The following is a description of a gene set: Human Gene Set: PID_THROMBIN_PAR1_PATHWAY PAR1-mediated thrombin signaling events studied in species Homo sapiens from publication Schaefer CF, Anthony K, Krupa S, Buchoff J, Day M, Hannay T, Buetow KH (PMID 18832364), and this is the list of marker genes: F2RL2, PKN1, RHOA, DNM1, PRKCG, ZYX, GNAI3, MYL2, F2R, GNAZ, SNX1, GNA12, GRK3, F2, PLCB2, ROCK1, GNAI1, DNM2, NOS3, GNAQ, GNB1, PLCB3, GNA15, ARRB1, PRKCB, GNG2, TRPC6, PIK3R1, PLCB1, GNAI2, ARHGEF1, GNAO1, SNX2 (NCBI Gene Id 6643), GNA14 (G protein subunit alpha 14), ARHGDIA, PIK3CA, PRKCA, GNA13, ROCK2, AKAP13, GNA11, PRKCD, VASP